The following is a description of a gene set: Subcutaneous hemorrhage Human Gene Set: HP_SUBCUTANEOUS_HEMORRHAGE This term refers to an abnormally increased susceptibility to bruising (purpura, petechiae, or ecchymoses). species: Homo sapiens, and this is the list of marker genes: FOXE3, RUNX1, RRAS2, GIMAP5, TBL1XR1, ATP7A, ZBTB16, LYN, PRKACA, CDH23 (cadherin related 23), FGG, HOXA11, FANCE, MAT2A (methionine adenosyltransferase 2A), NPM1, PLAU, PDE11A, NFIX, SCARB2, TERC, PEPD, CFHR1, SERPINF2, F7, GP1BA, COL1A2, GATA1, STXBP2 (syntaxin binding protein 2), LZTR1, PTEN, HPS1, GGCX (NCBI Gene Id 2677), APOA1, PLCG1, HCK, NBEAL2, FKBP14, PML, CREB3L1 (NCBI Gene Id 90993), C1S, LOX, SLFN14, JAM2, ADA2, HPS6, GATA2, NRAS, LMAN1, PRDM5, RASGRP2, ZNF469 (zinc finger protein 469), OCLN, MFAP5, ARVCF, IRF2BP2, TPM4, DPP9, COL5A1, MCFD2, COG8, RIN2, FBN1, MYH9, AIP, PTPN22, TBX1, MAPK1, SLC20A2, NR3C1, F8, RAF1, WAS, GP6 (NCBI Gene Id 51206), FCGR2C, RARA, CD19, HPS4, COL3A1, EMILIN1, PYCR1, SLC39A13, HEY2, SBDS, UFD1, F10, NFKB1, CASP10 (caspase 10), F2, ETHE1, FASLG, EPHB2, IPO8, FERMT3, HPS3, MYD88, MYH11, BLOC1S3, MVK, TNFRSF13C, SPRED2, PLEC, ITGB3, ADAMTS2, UNC13D, PROC, TGFBR1, CLCN7, ANKRD26, TGFBR2, CBL, RRAS, SLC2A10, FGA, ENPP1, HPS5, THSD4, RAB27A, BLOC1S5, STAT3, GNA11, FGB, SAMD9, TET2, SMAD4, HIRA, FUCA1, PDGFRB, SOS2, WIPF1, TNFSF11, DSE, SERPINE1, TGFB3, KDM1A, MAP2K1, NUMA1, APOE, PRKACG, BRAF, CHST14, STIM1, CD81, CD109, MRAS, SEC24C, TBXA2R, F9, HLA-DPB1, GP9, CTLA4, TREX1, JAK2, USP8, ATRX, GBA1, PLOD3, C1R, ITGA2B, NFKB2, SMAD3, SLC37A4, CR2, SOS1, JMJD1C, PRTN3, MYORG, PRF1, GP1BB, GFI1B, ETV6, AEBP1, FANCD2, TCIRG1, THBS2, DTNBP1, GNA14, ATP7B, SLC51A, C4A, HBA2, COMT, CFH, GSN, BGN, NLRP3, ABCC6, B3GALT6, MS4A1, ACP5, PRKAR1A (NCBI Gene Id 5573), MTAP, GNE, NABP1, SMAD2, F13A1, COL1A1, TNFRSF13B, VWF, CFHR3, CBS (NCBI Gene Id 875), USP18, RIT1, PROS1, SH2B3, MYLK, TNXB, NAGA, TERT, CALR, PDGFB, NEU1, PTPN11, XPR1, RREB1, ARL6IP6, FANCA, FYB1, ACTA2, ORAI1, SLC35A1, ELN, RASA2, BCOR, ARMC5, LYST, STAT5B, LYZ, MPL, IFNG, NTRK1, F5, FANCC, HBA1, TGFB2, EFEMP1, FAS, F13B, TFR2, COL5A2, TP53, FLNA, USP48, ITGA2, C2, P2RY12, PLOD1, SIK3, GNAS, PRKG1, TNFRSF1A, SNX10, PTPRJ, FIP1L1, KRAS, TNFSF12, ICOS, LCP2, HLA-DPA1, DCLRE1B, STX11